Given this list of marker genes EPM2AIP1, AJUBA, TTYH3, RPS24, TNFRSF12A, AOC3, UPF2, SMG1, GFPT1, DTX2, ADH1A, TC2N, PDGFB, LIN28A, ADH1B, MTSS1, STRADB, NRBP1 (NCBI Gene Id 29959), ACTC1, TRAFD1, FAM78A, CHKA, KLF17, SCML1, TRPC5, PALM, GRIA1, AHNAK, CRTC1, ACSL3, AQP6, TOM1L2, ZNF618, C1orf122, MFAP2, BLOC1S3, ICA1, SPATA6L, EGF, CUX1, RASGRP3 (NCBI Gene Id 25780), ZNF706, here is a description of the gene set: from publication Chen Y, Wang X (PMID 31504780) Human Gene Set: MIR3943 species: Homo sapiens Genes predicted to be targets of miRBase v22 microRNA hsa-miR-3943 in miRDB v6.0 with MirTarget v4 prediction scores > 80 (high confidence targets).